The following is a description of a gene set: from publication Maina EN, Morris MR, Zatyka M, Raval RR, Banks RE, Richards FM, Johnson CM, Maher ER (PMID 15824735) Human Gene Set: MAINA_HYPOXIA_VHL_TARGETS_UP Upregulation of hypoxia-inducible factors HIF-1 and HIF-2 is frequent in human cancers and may result from tissue hypoxia or genetic mechanisms, in particular the inactivation of the von Hippel-Lindau (VHL) tumour suppressor gene (TSG). Tumours with VHL inactivation are highly vascular, but it is unclear to what extent HIF-dependent and HIF-independent mechanisms account for pVHL tumour suppressor activity. As the identification of novel pVHL targets might provide insights into pVHL tumour suppressor activity, we performed gene expression microarray analysis in VHL-wild-type and VHL-null renal cell carcinoma (RCC) cell lines. We identified 30 differentially regulated pVHL targets (26 of which were 'novel') and the results of microarray analysis were confirmed in all 11 novel targets further analysed by real-time RT-PCR or Western blotting. Furthermore, nine of 11 targets were dysregulated in the majority of a series of primary clear cell RCC with VHL inactivation. Three of the nine targets had been identified previously as candidate TSGs (DOC-2/DAB2, CDKN1C and SPARC) and all were upregulated by wild-type pVHL. The significance for pVHL function of two further genes upregulated by wild-type pVHL was initially unclear, but re-expression of GNG4 (G protein gamma-4 subunit/guanine nucleotide-binding protein-4) and MLC2 (myosin light chain) in a RCC cell line suppressed tumour cell growth. pVHL regulation of CDKN1C, SPARC and GNG4 was not mimicked by hypoxia, whereas for six of 11 novel targets analysed (including DOC-2/DAB2 and MLC2) the effects of pVHL inactivation and hypoxia were similar. For GPR56 there was evidence of a tissue-specific hypoxia response. Such a phenomenon might, in part, explain organ-specific tumorigenesis in VHL disease. These provide insights into mechanisms of pVHL tumour suppressor function and identify novel hypoxia-responsive targets that might be implicated in tumorigenesis in both VHL disease and in other cancers with HIF upregulation. species: Homo sapiens Genes up-regulated by hypoxia in RCC4 cells (renal cell carcinoma) engineered to stably express VHL off a plasmid vector., and this is the list of marker genes: CLDN4, SERPINE1, F3, CDKN1C, SLC16A3, NREP